The following is a description of a gene set: studied in species Homo sapiens Human Gene Set: GNF2_RAB3A Neighborhood of RAB3A Neighborhood of RAB3A RAB3A, member RAS oncogene family in the GNF2 expression compendium, and this is the list of marker genes: RUNDC3A, GRM3, SV2B, SH3GL2, RALYL, GABBR1, FXYD7, GAP43, NDRG4, RAB3A, EPB41L1, SULT4A1, SYT11, SNAP91, SV2A, KIF5C, RGS7, SYT1, RAB6B, KCNQ2, SLC12A5, DNM1, ARNT2, RCAN2, ARHGEF9, DPP6, GABBR2, STXBP1, FAIM2, VAMP2, GDI1, TAGLN3, CAMK2N1, KIF3C, EHD3, SYN1, NRCAM